Given this list of marker genes GRIN3A, HTR1B, PICALM, ZDHHC17, COPS4, CACNA2D2, ARL6IP5, STX2, SNX4, GHRH, SLC29A1, SEPTIN3, HAP1, PCDH8, BCL2L1, ATP8A1, SEMA4C, PTPRD, BLTP1, RGS9, BAIAP3, RAB11A, P2RY1, RAB3C, DSTN, THY1, GRIK5, S1PR5, GRIN2D, SV2C, KCNC1, PDYN, DNM1L, BRAF, SUMO1, NLGN2, TOR1A, CHRNA4, P2RX7, PPP1CA, CNTNAP4, DOC2A, ZNF804A, CDK5, PSEN1, GPM6A, CALB1, SLC2A4, GPER1, SYAP1, PTK2B, SYNJ1, AP1S1, CBARP, PICK1, EGFLAM, BLOC1S6, SYT4, ARFGEF2, CADM3, CACFD1, PPFIA1, ATCAY (ATCAY kinesin light chain interacting caytaxin), PPFIBP1, GNRH1, IGSF8 (NCBI Gene Id 93185), SNCB, LIN7A, SLC1A6, SLC18A3, CPLX4, SNCAIP, OPHN1, OTOF, GRIK3, KCNA2, AP2B1, PRUNE2, ADORA1, FXR1, SH3GL1, CDK5R2, SLC6A11, CALM1, GAP43, DNMBP, AAK1, RIMS1, SLC17A8, STX10, PCLO, SCGN, GRK2 (NCBI Gene Id 156), DRD1, SLC6A13, SHROOM4, SLC18A2, SLC9B2, SMCR8, UBE2I, S1PR2, STX12, HRH3, BEST1, PACSIN1, PRNP, PSEN2, OXT, PRRT2, RAB3D, GRAP, ERC2, APBA1, CNTN1, CRHR2, GDI1, SNAP25, CPLX1, RAB3GAP2, NAPEPLD, TBC1D24, YWHAG, WNT3A, SYT13, AMPH, ATP6V0A4, NTF4, ARPC2, ATP6V1F, SYNDIG1, PRAF2, NPY5R, CNTN5, RAB7A, PPFIA4, PNKD, GRM2, CASR, ACTG1, METTL5, BIN1, SNX9, PTPRS, DAAM1, MCTP1, CALM2, SYT7, SLC22A1, SRCIN1, STX6, UBE3A, PIK3C3, TRIM9, RMDN3, PCDH17, UNC13C, SLC4A10 (solute carrier family 4 member 10), ATP6AP2, LRFN2 (NCBI Gene Id 57497), CASK, EPS15L1, RAB5B, NTS, CNTN6, SNAP47, APH1A (NCBI Gene Id 82089), SCN10A, PDZD11, MTMR2, PIAS3, NEFL, NRN1, ITSN1, UCN3, ANO1, SLC6A17, COPS5, RPH3A, KCNC3, ATP6AP1, ATP6V1G1, SLC35F1, SLC22A3, KCNJ10, ATP2B4, SLC1A2, GABBR1, RAB40B, PDE2A, SLC29A4, TMEM163, NPFF, APP, CNR1, PI4K2A, PNISR, DRD2, GAK, ABCC8, PIANP, VPS16, PSENEN, RAB5A, ATP6V0A1, IL31RA, SLC6A4, MX2, SLC8A1, SUMO2, NMU, KCNJ9, VAMP4, S1PR1 (sphingosine-1-phosphate receptor 1), CLCN3, CLTB, SGIP1, SLC35G2, ARHGAP44, RAB3A, GPR158, HCN1, SNCA, SLC4A8 (solute carrier family 4 member 8), EFNB3, CHRNA5, CTNNB1, SEPTIN5, VAPB, ROR1, ADORA3, NECAP1, SLC8A3, CLTA, C1QL1, NTNG2, SVOP, LIN7B, CADPS2, SYNGR4, CACNA2D3, DNAJC6, SYPL1, SYNJ2, DVL1, PPFIBP2, PDLIM5, SYN1, PIAS1, VAC14, SLC24A2, DLG4, DENND1A, LRFN3, USP14, FBXO45, CACNB2, SCAMP1, SNPH (NCBI Gene Id 9751), TH, PPFIA2, ITGA3, PARK7, CABP4, PRSS12, SEPTIN8, DMXL2, CACNA2D1, SLC8A2, ATP6V0E2, RPS27, C1QBP, NECTIN1, AP3S1, VPS52, KCNJ8, BSN, DBNL, SYT2, ITGA2, SYN2, PPFIA3, ATP6V1H (NCBI Gene Id 51606), NTNG1, DDN (NCBI Gene Id 23109), S1PR4, UNC13B, HIP1, PNOC, SEMA7A, MME, S1PR3, SCRIB, GRIK4, DOC2B, DTNBP1, ELK1, TSPOAP1, RGS7, RYK, NPTX2, GIPC1, NPY2R, MICAL1, CPLX2, FUS, UNC13A, NAPA, PRRT1, FLRT2, EFNB2, FLOT1, SLC1A1, TRIO, AP2A2 (NCBI Gene Id 25955), AP2S1, SYNGR1, TMEM230, USH2A, ARF6, RAB27B, SYT6, CANX, PIP5K1C, SYNGR2, SNCG, RAB3B, SLC30A3, NRXN2, SLC6A12, ZNRF2, AP2M1, TPRG1L, CRHBP, SLC6A9, FER1L5, NLGN3, CHRM1, ATP6V0D1, KIRREL3, GIT2, RABAC1, RAB11B, VAMP2, RAB26, VPS18, CAPN2, TNIK, HTT, PRKN (parkin RBR E3 ubiquitin protein ligase), EHD1, GRIPAP1, SEPTIN1, SRPK2, EFNB1, KCNC4, BORCS5, RAC1, SLC18B1, ATP6V1C1, PPP3CC, ITSN2, VPS45, UCN, OSBPL2, KCTD8, GRM7, P2RX1, GRM3, TRPC5 (transient receptor potential cation channel subfamily C member 5), CAP1, ICA1, KIF1B, AP3M2, TANC1, LPAR2 (lysophosphatidic acid receptor 2), EPHB2, VTI1B, SH3GL2, RAP1A, STX16, KCNQ5, SYNPR, IQSEC1, CDH2, AP3B2 (NCBI Gene Id 8120), SYT12, VAMP1, SCN9A, RIMS4, ATM, SEPTIN4, SYP, ADAM11, ADORA2B, KIF21A, RIMS3, ERBB4, SV2B, SENP7 (SUMO specific peptidase 7), CNRIP1, GRM4, SYN3, STX19, NF1, SLC6A3, GABRA2, PPT1, SLC17A5, KCNC2, FCHO2, FBXL20, SYT5, BACE1, RAB13, TMED9, GNAO1, MYOF, DNM3, RAB12, KCTD12, CTTNBP2, STON2, LGI3, CLN8, SNAPIN, DAO, RPH3AL, CRMP1, SCAMP5, AP1G1, KCNA1, ADCY1, GOT1, SLC6A1 (NCBI Gene Id 6529), AP3D1, MT3, PPP1CC, SLC18A1 (NCBI Gene Id 6570), SNAP23, C1QA, STXBP5, STX1B, GSK3B, CALM3, MCTP2, NOS1, PLD2, CAD, STXBP1, ATP2B1, FXR2 (FMR1 autosomal homolog 2), ATP2B3, STON1, RAB40AL, GRIN1, TRAPPC4, BRSK1, SCRN1, PFN2, NOG, SH3GL3, SENP5, RAB40A, SLC2A13, GABRR1, DGKI, SLC5A7, CLCN5, VTI1A, C1QC, GRIA1, ATP6V1B1 (ATPase H+ transporting V1 subunit B1), WFS1, SLC32A1, LAMP5 (NCBI Gene Id 24141), SNAP91, RAB8A, SNAP29, SRSF10, CHRNA6, RAD51, SLC22A2, KIF2C, ATP6V0C, FAAH, UBE2M, GABRA5 (gamma-aminobutyric acid type A receptor subunit alpha5), APBA2, DISC1, GIT1, ERBB2, CDK16, ROGDI, KCNK9, GRIN3B, CYP46A1, SYT9, ADRA2A, CHRM2, LAMP1, CHRNB3, STX3, SYT10, SLC35D3, ERC1, EPHA4, NTRK2 (neurotrophic receptor tyrosine kinase 2), HTR2A, SPHK1, TNN, TSNARE1, NGF, WNT7A, GRIN2A, SLC17A6, NPTN, SLC30A10, MX1, MFF, ASIC1, KCNK2, PHF24, RPL22, PDE4B, PTPRN, EEA1, LPAR1, ATP6V1A, RGS7BP, ELFN1, SLC2A8, TLN2, OPRD1 (opioid receptor delta 1), GUCY1B1, FZD3, STXBP2, CLCN4, PTPRN2, BDNF, RPS6, CDH8 (NCBI Gene Id 1006), KCNH1, HCRT, NGFR, FXYD6, CACNB4, SEPTIN6, DYSF, NCSTN, SYT11, ATP6V1G3, GRK3, FLRT3, KCTD16, SLC2A1, SPTBN2, SV2A, NRXN1, RIMS2, KCNJ3, SLC40A1, STX1A, IGSF21, BAIAP2, CTNNA2, CLN3, DGKQ, LRRK2 (leucine rich repeat kinase 2), ADGRL1, YWHAH, NRXN3, ATP6V1D (NCBI Gene Id 51382), GRIK1, RAB8B, BTBD8, OPRK1, GPR151, EFR3A, NPY, GNB5, ACTB (NCBI Gene Id 60), FMR1, RABGEF1, TULP1 (NCBI Gene Id 7287), MRTFB, CNTNAP2, STXBP3, NTF3, TPBG, NECAB2, CALB2, GAD2, ATP6V1B2, NDEL1, SLC17A7, SYT1, PENK, DNM2, CADPS, PRKCB, AP2A1, AP3S2, CPLX3, STX11, PHAF1, SLC6A2 (NCBI Gene Id 6530), ANP32E, LRRC4B, USP5, STX7, NLGN1, GRIK2, TAFA4, ATP6V1E1, ATP6V1G2, NTSR1, ADAM23 (NCBI Gene Id 8745), ZNRF1, GAD1, AP1B1, CNGB1, KCNA6, SENP1, VPS35, DNM1, DNAJC5, SYNGR3, CDH10, PRKCG, GLRA3 (glycine receptor alpha 3), LIN7C, C9orf72, RAB40C, GABRB1, CTBP1, ADORA2A, NUFIP1, RNF112, SYT8, ADCY8, SYPL2, RAB33B, here is a description of the gene set: Human Gene Set: GOCC_PRESYNAPSE The part of a synapse that is part of the presynaptic cell. studied in species Homo sapiens